The following is a description of a gene set: Mouse Gene Set: RUAN_RESPONSE_TO_TNF_UP species: Mus musculus Troglitazone (TGZ), a member of the thiazolidinedione class of anti-diabetic compounds and a peroxisome proliferator activator receptor-gamma (PPAR-gamma) agonist, restores systemic insulin sensitivity and improves the full insulin resistance syndrome in vivo. The mechanisms underlying its in vivo function are not understood. Here we investigated the potential functional interaction between PPAR-gamma and NF-kappaB in adipocytes. We show that TGZ selectively blocked tumor necrosis factor-alpha-induced and NF-kappaB-dependent repression of multiple adipocyte-specific genes and induction of growth phase and other genes. This occurs without interfering with NF-kappaB expression, activation, nuclear translocation, or DNA binding and without suppressing NF-kappaB-dependent survival signals. Notably, the expressions of some tumor necrosis factor-alpha-induced genes in adipocytes were unaffected by PPAR-gamma activation. In reporter gene assays in HeLa cells, ectopic expression of PPAR-gamma abolished induction of a NF-kappaB-responsive reporter gene by the p65 subunit (RelA) of NF-kappaB, and the inhibition was further enhanced in the presence of TGZ. Conversely, overexpression of p65 inhibited induction of a PPAR-gamma-responsive reporter gene by activated PPAR-gamma in a dose-dependent manner. The inhibitory effect was independent of the presence of NF-kappaB-binding sites in the promoter region. Other NF-kappaB family members, p50 and c-Rel as well as the S276A mutant of p65, blocked PPAR-gamma-mediated gene transcription less effectively. Thus, p65 antagonizes the transcriptional regulatory activity of PPAR-gamma in adipocytes, and PPAR-gamma activation can at least partially override the inhibitory effects of p65 on the expression of key adipocyte genes. Our data suggest that inhibition of NF-kappaB activity is a mechanism by which PPAR-gamma agonists improve insulin sensitivity in vivo and that adipocyte NF-kappaB is a potential therapeutic target for obesity-linked type 2 diabetes. Adipocyte abundant genes up-regulated in 3T3-L1 cells (fibroblasts induced to differentiate to adipocytes) in response to TNF. from publication Ruan H, Pownall HJ, Lodish HF (PMID 12732648), and this is the list of marker genes: Ifngr1, H2-K2, Ubd, H2-T23, Stat1, Serpina3n, Dcn, H2-D1, Gbp2, Tap2, Thrsp, Cp, Abca1, Hp